The following is a description of a gene set: studied in species Homo sapiens Vasopressin regulates renal water homeostasis via Aquaporins Human Gene Set: REACTOME_VASOPRESSIN_REGULATES_RENAL_WATER_HOMEOSTASIS_VIA_AQUAPORINS, and this is the list of marker genes: GNB5, PRKACA, GNG5, ADCY2, GNG8, AVP, GNGT2, GNGT1, PRKAR1A, ADCY8, PRKACB, ADCY3, ADCY7, ADCY5, GNAS, GNG12, RAB11FIP2, GNB3, ADCY9, RAB11A, PRKACG, PRKAR1B, GNB1 (NCBI Gene Id 87729), ADCY4, PRKAR2B, GNB4, GNB2, AQP3, MYO5B, ADCY6, GNG10, GNG7, AQP4, GNG11, AVPR2, GNG13, GNG4, AQP1, ADCY1, AQP2, PRKAR2A, GNG3, GNG2